The following is a description of a gene set: Human Gene Set: HP_SHORT_UPPER_LIP Decreased width of the upper lip. studied in species Homo sapiens Short upper lip, and this is the list of marker genes: EMC1, VAC14, CPLX1, FGFRL1, NSD2, LETM1, CTBP1, AMPD2, ATRX, FIG4, GRIA3 (NCBI Gene Id 2892), TWIST2